The following is a description of a gene set: Genes predicted to be targets of miRBase v22 microRNA hsa-miR-376b-5p, hsa-miR-376c-5p in miRDB v6.0 with MirTarget v4 prediction scores > 80 (high confidence targets). Human Gene Set: MIR376B_5P_MIR376C_5P from publication Chen Y, Wang X (PMID 31504780) studied in species Homo sapiens, and this is the list of marker genes: STPG4, ADH5, LATS2, WIPF3, EXOSC3, TMEM204, RORA, ASB15, GLS, PHIP, ZNF34, NEUROG2, EDNRB, NF1, SLITRK1, ZKSCAN3, GLT8D2, SCN1A, MTO1, ZBTB20, BCOR, IL1RAP, PGR, USP38, SLC2A2, CLVS2, APEX1, FAM81A, C5orf15 (chromosome 5 open reading frame 15), SLC39A13, PICALM, AAK1, TEP1, CDH6, GDF5, TMEM108, NAIP, MACF1 (NCBI Gene Id 649183), ALCAM, NFKBIA, EPG5, TMEM18, NFE2L3, GPM6B, FIGN, ZNF74, SCLT1